Given this list of marker genes ZNF597, GCLM, SAMD12, ALX3, NTRK2, NCOA1 (nuclear receptor coactivator 1), GJB2, SETD5, SMARCA5 (NCBI Gene Id 8467), LAPTM5, EXOG, RNF4, RERG (RAS like estrogen regulated growth inhibitor), SPAG17 (sperm associated antigen 17), CAPZB, CUL2, NECTIN4, CLEC4M, KRT6C, LZTR1, MUL1, DLEU7, SMO, RGS7, CACNA2D4, NCOA4 (nuclear receptor coactivator 4), ERBB4, GVQW3, CD274, DGKB, TMEM170A, PLXDC1, RASSF4, MPI, AGT, TIMP2, ST3GAL1, FKBP1A, AFF3, PTPRJ, A1CF, SIRPB1, BTN2A2, AMER2, ARHGAP31, NONO (non-POU domain containing octamer binding), KLHL29, TRPC3, PRRG3, CNTNAP2, ACP3, DLL4, TMEM100, PMP22, NR6A1, LRP6, TCHH, PRLR, STX1A (NCBI Gene Id 6804), KLF6, FAM168B, HOXA9, MCAM, B3GALT1, NRIP3, NCOA2, EFHC1, TNS1, PLCL1, CREB5, NMT2, NBPF20, F2RL2, FAM120A, CAMK1G, NBPF8, FER1L6, KDM2A, IDI2, PIK3C2B, NTRK3, THBS1, ETNK2, NBPF3, TCF21, CD209, TMEM95, WDHD1, SYNJ1, U2SURP, ATP6V0E1, CLMN, DGKA, GFRAL (GDNF family receptor alpha like), MITF, PTPN7, NBPF9, AKT1, SNPH, CHST2, NBPF12, FUBP3, CAMK1D, ILF3, RELCH, DBR1, HIF3A (hypoxia inducible factor 3 subunit alpha), YDJC, GALK1 (NCBI Gene Id 2584), GGCX, MTM1, LIX1L, IFT80, HIP1, DIPK2B, WIPF3, NBPF11, S100B, WLS, KCNS1, TMEM26, NBPF15, ACVR1B, SCN8A, MOB3A, AR, KIF1B (kinesin family member 1B), USP51, ITPRID2, LARP4B, YBX2, MOGAT3, ERLIN2, TRPC5, PPP1R13B, EIF4G3, PDE1B, TIMM10B, PLEC, KRTAP4-12, PAX5, PLPP5, LRRC20, C1orf74, HEPACAM, MOB3C, AGPAT4, SYT7, RAB11FIP4, RUSC2, ST14, TMEM199, KCNC4, RFESD, NBPF1, ALX4, EBF3 (NCBI Gene Id 276717), ADARB2, SUMF2, SPATA31H1, SCAI, NOVA2, MLLT1, RALGAPA2, ESYT1, MTCL2, PRSS22, TRAF4, KBTBD2 (kelch repeat and BTB domain containing 2), TACC1, TSPAN6, PDS5A, UNC80, KRT77, NBPF14 (NCBI Gene Id 375081), FBXO42, XKR4, TSC22D1, RASSF2, here is a description of the gene set: Genes predicted to be targets of miRBase v22 microRNA hsa-miR-4443 in miRDB v6.0 with MirTarget v4 prediction scores > 80 (high confidence targets). from publication Chen Y, Wang X (PMID 31504780) studied in species Homo sapiens Human Gene Set: MIR4443